The following is a description of a gene set: studied in species Homo sapiens from publication Fan X, Dong J, Zhong S, Wei Y, Wu Q, Yan L, Yong J, Sun L, Wang X, Zhao Y, Wang W, Yan J, Wang X, Qiao J, Tang F (PMID 29867213) Human Gene Set: FAN_EMBRYONIC_CTX_MICROGLIA_3, and this is the list of marker genes: C1QB, LGMN, C1QC, TBXAS1, MERTK, SLC1A3, ALOX5AP, SLCO2B1, CTSC, CREG1, CD68, TREM2, FOLR2, CTSD, GPR34, CTSB, ADAM28, ASAH1, P2RY12, SIGLEC10